Given this list of marker genes HLA-DPA1, COLEC11, CTLA4, YARS2, C1S (complement C1s), TXNDC15, EPG5, ATPAF2, MAB21L1, RAD51, SON, IBA57, WNK3, EIF4A2, LAS1L, AARS1 (NCBI Gene Id 16), OSGEP, KIAA0586 (NCBI Gene Id 9786), CSGALNACT1, B9D2, CD247, DOCK3 (dedicator of cytokinesis 3), FLNB, DNAAF6 (dynein axonemal assembly factor 6), UBA1, HYMAI (hydatidiform mole associated and imprinted), SOST, POMGNT1, HNRNPH2, WBP4, LZTR1, DNAJC30, BBS12, ABCD4, PITX2, OTUD6B, TCF3, BICRA, DBR1, IPO8, SLX4, PARN, SUPT16H, TMEM270, U2AF2, LMNA, FAM50A, RPS28, CRIPT, IARS2, BCR, AGRN, ERCC3, ATP6V0A2, PLAA, CEP55, WDR26, SALL4, ABAT, MOGS, DNAAF5, IVNS1ABP, SEC24C, IFT43, MAN1B1, FIG4, FAM149B1, NEB, SUFU, GTF2IRD1, NDUFB11, KCNJ5, KIF7, MAGEL2, OCRL, BBS4, NOTCH2, INTU, KIF21A, GOLGA2 (NCBI Gene Id 2801), CUL4B, TP53RK (NCBI Gene Id 112858), TBX5, TAPT1, STX1A, AMER1, TAF4, FANCI, DHX9, FLNA, COL11A1, TGIF1, TUBA1A, SLC25A24, BTK, HDAC8, COG8, RTTN, OSTM1 (NCBI Gene Id 28962), TMEM216, CSPP1, HMOX1 (heme oxygenase 1), RYR3, H3-3A, TAFAZZIN, KDM6A, CDT1, TAP2, PEX12, SEC61A1, RPS10, SLC26A2, SEC31A, TNFRSF9, ACTG2, PCDHGC4, DGCR8, UBA2, BRAF, RPS7, ODAD1, CHUK, BANF1 (barrier to autointegration nuclear assembly factor 1), RNF113A, CANT1, RHOA (ras homolog family member A), PIGO, IFT172, C1GALT1C1, FTO, SIM1, GATA4, TRIP4, RAB33B, TBK1, RERE, CHN1, PGM1, COL9A3 (collagen type IX alpha 3 chain), HBB, SYT2, HSD17B4, HSPG2, SETD5, CCDC40, ZMYND10, BUD23, ARMC9, BUB1B, IL2RG, TP63, NME8, GLDN, SMCHD1, MGAT2, MED12, CHSY1, CDC42BPB, SIX1, STAMBP, RFXAP, NFASC, FDFT1, NSUN2, BPNT2, SLC12A2, CDC73 (NCBI Gene Id 79577), IGFALS, COL6A1, PPP1R12A, RPS29, TBC1D2B, CA2, PTPN22, CHST3, NUP88, TERC, TTC8, PEX5, SLC5A7, NELFA, RPS27, ZC4H2, FOCAD, CHD6, CEP295, HS2ST1, DNAAF1, IL6ST, NCF4, CEP290, TENT5A, INTS11, IFT74, SERPINH1, CSNK2B, CDC45, YRDC, EDNRA, COL11A2, TPM2 (NCBI Gene Id 7169), BRIP1, DNMT3A, DOCK8, BICD2, GTF2H5, SLC2A10, RPL31, FANCF, FRMPD4, NSMCE2, ARHGEF38, WDR4, CFI, DNAI2, ABCD1, CTNND2, PNP, DPH5, NCF1, UBAP2L, PLEKHM1 (pleckstrin homology and RUN domain containing M1), CTDP1, HYOU1, RPS20, FOXC2, TMEM107, MDM4, EXTL3, PHF21A, CTC1, FZD2, KLHL41, AP1S2, CREB3L1, DEAF1, MIF, CTSK (cathepsin K), ADAT3, STK36, BRCA1, NHS, MAN2C1, PRKCD, TPRKB, BRF1, ERMARD, ADGRG6, ASPH, HERC1, CSNK2A1, WDR62, HACD1, TRPM3, ATP6V1E1, MAP3K20 (NCBI Gene Id 51784), RFC2, SATB2, KAT6A, DKC1, ATP6AP2, XPA, TRAIP, CHD8, RPL15, IRF2BP2, SLC10A7, ZNF668, AKT1, MECP2, COL2A1, FBXO31, CLIP2, FANCD2, COL1A1 (NCBI Gene Id 4970), SIN3A (NCBI Gene Id 25942), TARS1, ATR, AGA, CTCF, DSE, OTUD5, POLA1 (DNA polymerase alpha 1, catalytic subunit), TAF6, JMJD1C, ZBTB11, PSMC1, GLI2 (GLI family zinc finger 2), FUT8, NCF2, PRKAR1A, ZEB2, LARP7, BMP4, GRIA3, LEMD3, PSAT1, RPGR, MYL11, DVL1, MYH8, MRAS, ARSL, MYPN, DZIP1L, PIK3R1, CFAP300, DNAH7, CNTN1, RAP1B (NCBI Gene Id 5908), ZNF699, COX7B, SCN9A, DPYSL5, DDX3X, SPRTN, NBN, ORC1, DHX30, SLC25A1, DOCK6, BIN1, ELANE (NCBI Gene Id 6417), BUB1, AGL, ESCO2, PEX3, SEC23A, FUCA1, METTL27, VPS53, DLG1, RSPH3, PIGA, PKHD1, FKTN, IDUA, IDS, MAPRE2, WNT5A, CPE, CDH11, ADAMTS10, KDM4B, MLXIPL, LIG4, FOXJ1, SIX3, MBD5, KCNJ2, VPS35L, TRRAP, UBB, PTH1R, RSRC1, UBE3A, EIF4H, POU1F1, COL1A2 (NCBI Gene Id 1278), CD79B, ARX, SCARF2, GHR, DGCR2, EDEM3, DYM, ZBTB20, COL12A1, ERBB3 (NCBI Gene Id 619500), COL9A2, DNAH11, PEX19, CFAP52, FLII, SPAG1, HUWE1, MAP2K2, TBX4, RFX7, SMPD4, NCAPG2, PLA2G6, CYBC1, MITF, ODAD4, NECTIN1, BPTF, PTPN2, KATNB1, MEGF8, KIF26A, STAT4, FILIP1, RAB18, RFX5, ALX4, PCGF2 (NCBI Gene Id 7703), XRCC4, MAMLD1, IRX5, SEC24D, MYMK, RAF1, PQBP1, NEPRO, PIGB, BCL11A, KCNK9, CPLX1, NAA10, SLC12A6, ASXL3, ZNF335, LGI4, HIRA, SMC5, ZNF341, NUP188, SH2B1 (NCBI Gene Id 25970), RPL9, SCAPER, DPM2, LAMA2, KCTD1, ERI1, PEX1, ACTA1, TRIM37, LTBP3, ERCC8, SBDS, SNRPB (small nuclear ribonucleoprotein polypeptides B and B1), MESD, DSTYK, APC2, CENPF, RPS6KA3, CLTCL1, MAPKAPK5, RFXANK, MAD1L1, KPTN, DPYD, GMNN, FANCA, STK4, RFT1, MINPP1, CFAP45, MARS1, SH3KBP1 (SH3 domain containing kinase binding protein 1), UPF3B, NME5, SLC35A3, TBCD, SOX18, POLR1B, NPR3, PLK4, DDB1, CHST14, YY1, MGP, IFT80, ECEL1, NUP85, ZDHHC9, CCNK, RIC1, PAX7, KRAS, PLCB4, PIGW, LARGE1, EXOSC1, MID1, ACSL4, RPS17, PIEZO1, CBFB, C12orf57 (NCBI Gene Id 113246), SCYL2, XRCC2, CRPPA, TNFSF11, UNC119 (NCBI Gene Id 9094), CFL2, COG6, PRIM1 (DNA primase subunit 1), SHH, FOXF1, RPL27, GFPT1, MAP3K7, MYO9A, EZH2, NSD1, PRRX1, TCTN2, HLA-DPB1, BNC2, CLCN7, TFAP2A, SLC26A9, PALB2, TRIP11, SHOX, BDNF, PYCR2, DYRK1A, PRR12, GALNS, DHODH, LRBA, FOXE3, TCTN3, TTN, PI4K2A, PIK3CA, GSC, SHANK3, ADAMTS2, WDR35, HNF1B, TMCO1, MMP2, ZNHIT3, HYDIN, TMEM67, RAPSN, C4B, CFAP418, TINF2, TFE3, LAMB2, WWOX, MAP2K1, ACTG1, CDCA7, COLQ, NSRP1, MTX2, RUSC2, CIITA, CRKL, ARHGAP29, SC5D, TCTN1, INSR, GRIA4, ERCC6, SPRED2, DPAGT1, MRPS22, FANCC, CAVIN1, RSPRY1, ICOS, EFTUD2, FANCE, GNA11, RFWD3, HDAC6, IGF1R, KIF14, GNAS, ANK1, ARID1B, POC1A, H3-3B, PTPN11, MCM5, PRDM13, BRCC3, GPR101, SF3B2, PIGQ, GABRA3, CTBP1, FGFR3, CCDC65, PTEN, RHOBTB2, CHRNE, PKDCC, CTU2, COBLL1, RARB, AIP, PEX13, RAD21, ALG14, PHGDH, TNRC6B, ROBO1, SNRPN, SLC39A7, ANTXR1 (ANTXR cell adhesion molecule 1), CNOT2, FANCL, HBA1, SVIL, PIGU (phosphatidylinositol glycan anchor biosynthesis class U), TGFBR2, CD79A, ADGRG1, UHRF1, KDM5A, ALDH1A2, LBR, NGF, PLXND1, PRUNE1, TBX1, STRA6, DNAAF11, TRIO (NCBI Gene Id 7204), HNRNPH1, VAC14, RNU4ATAC, AFG2B, OPHN1, HMX1, BBIP1, CCN2, FBXO28, CFAP74, PAH, SLC4A10, SOS2, EXOSC5, KCNH1, PGM3 (NCBI Gene Id 5238), PLAG1, GJA8, IGHM, BBS5, IFT27, ANKLE2, FBXO11, SLC6A8, STEEP1, AHDC1, DNAAF4, DLX4, TSR2, POLE, IGHG2 (NCBI Gene Id 3501), ASNS, EIF4A3, COASY, TUBGCP2, GTF2E2, YARS1, CLCN4, AP3D1, CDKN1C, GLE1, BRWD1, RPL10, ANO5, THOC6 (THO complex subunit 6), NFKB1, HNRNPR, HFE, COG5, DDB2, MAPK1, OBSL1, RREB1, GRB10, PSMB8, SLC29A3, FARS2, SPEG, BLTP1, ASXL2, TCIRG1, PEX11B, LOX, NFKB2, CEACAM3, RBM10, NOP10, PUS7, FGFR2, EHMT1, HNRNPU, MAT2A, USB1, PIGN, TOE1, GP1BB, RELN, SPECC1L, TMEM165, SH3PXD2B, SIX5, ABL1, PTCH2, ANKRD11, TRMT1, BRAT1, BBS10, RPGRIP1, MYL2, MSX1, SEMA5A, BBS9, KNL1, LRP4, COG7, LEMD2, PEX6, MAGT1, GPC6, GORAB, FCGR2A, SMAD4, IGLL1, POGZ, MAD2L2, ALMS1, NBAS, NXN, NEK1, DICER1, ZMIZ1, POLR1C (NCBI Gene Id 9533), PGAP2, HPDL, DNAH1, VAMP1, GRIP1, FGFR1, COG1, LMOD3, PIGY, D2HGDH, PUS1, DOK7, APC, PRKG2, TNFRSF13C, GPC3, ERCC2, TERT, H4C5, ROR2, DLK1, IL2RA, TPM3, BLM, LRRC32, RYR1, UNC80 (NCBI Gene Id 84540), IQSEC2, SDCCAG8 (NCBI Gene Id 10806), TAP1, PEX2, TWIST2, GATAD2B, TFAP2B, GLB1, GTF2IRD2, CARS1, CCDC32, COL5A2, EXT2, STXBP2, MYCN, MFAP5, BCAP31, KAT5, SPEF2, ACTB, LRPPRC, EBF3, PDE6D, DPM1, IGF2, PRRT2, PPARG, C1R, GJA5, RPL8, PEX10, PURA, IRF6, PI4KA, IL1RAPL1, NONO, CWC27, CAMTA1, JARID2, FOXG1, TXNL4A, TSEN54, ARVCF, AP2M1, SRPX2, DIS3L2, FANCM, AGPAT2, MEN1, FRA10AC1, NUP133, FKBP6, NARS1, GCLC, PGAP3, COG4, CFAP221, AP4M1, SLC35C1, KCNC2 (potassium voltage-gated channel subfamily C member 2), GBA1, FCGR3A, OCLN, CCBE1, LETM1, WNT7A, TBXAS1 (thromboxane A synthase 1), TTC12, RAI1, CLXN, RNF168, PREPL, ASCC3, KIF11, DHCR7, EP300, AEBP1, NFIX, EMG1, ALG13, GNPTAB, DRC1, PIEZO2, IL21R, DPH2, AFF4, PLAAT3, BUB3, NR2F1, SLC6A14, NDP, ESS2, BGN, ARNT2, DNAI1, CD96, NEK10, SETBP1, CDK5, MAF, TBX15, UBE3B, BMPER, CCDC103, BBS7, RAC2, CC2D2A, RSPH1, P4HB, COL9A1, ANKH, RNU12, SIX2 (SIX homeobox 2), DNAJC21, P4HTM, SPEN, PPP1R15B, RPL26, EDA (ectodysplasin A), RPS19, PHIP, RECQL4, FLCN, EED, VPS13A, CLIC2, H4C3, MEG3, HCCS, VANGL2, NPHP1, IRF8, PAX1, PDE11A, RPL18, ZFX, PYROXD1, ADAMTSL2, FOXI3, EYA1, GRHL3, RUNX2, PIGF, GNB2, PEPD, KMT2A, FOS, TNPO2, TUBB, CNOT1, PRTN3, NRCAM, TWIST1, CAV1, RAB23, KIFBP, RIT1, COL5A1, OTX2, TRPS1, CILK1 (NCBI Gene Id 51541), TASP1, GAD1, EMC1, TGFBR1, MUSK, RPL35, ARID2, RLIM, KCNE5, STAT3, NEDD4L, KCNN4, KMT2D, CREBBP, PSPH, THUMPD1, DDR2, ESAM, TUBB3, ODAD3, RECQL, B3GALT6, MAFB, IGKC, RTL1, RBBP8, DNAL1, SPOP, IKBKG, RB1, LAGE3, KL, PEX7, RTEL1, HELLS, BRD4, RAB34, DNAAF2, DNMT3B, EFL1, BSCL2, EXT1, HDAC4, EBP, TOPORS, ATM, RSPH9, UBE2A, LRRC56, XPC, SMS, SLC9A6, ACP5, PIGG, TBL2, MED13L, CDC6, CHRNG, SELENON, FOXE1 (NCBI Gene Id 7081), PDZD8, IL2RB, CENPE, CEP152, MYLK, HYLS1, ORC6, FGF3, TRIM32, TELO2, TAT, CSF1R, CASK, RPS15A, PDGFRB, SLC39A14, GNPAT, FBXW11, MAPK8IP3, CNTNAP2, MKKS, CACNA1G, NOTCH3, CLPB, GPKOW, NTRK1, HNRNPK, ANAPC7, NDST1, SMO, FANCG, SLC35D1, LTBP4, POMT2 (protein O-mannosyltransferase 2), SF3B4, MTM1, PAX6, MYBPC1, EFEMP2, ZBTB18, STT3A, RPS24, CDK10, LRRC8A, AUTS2, STAG2, DNA2, POLR1D, CCDC39, SLC11A1, CRTAP, SMG8, TGFB2, CENPJ, WIPF1, CLCF1, COL3A1, TGFB3, DGCR6, LRP2, C2CD3, MADD, RSPO2, ACBD6, SOBP, CUL7, TBX22, COL25A1, SETD2, BBS1, CAPRIN1 (cell cycle associated protein 1), IL11RA, ODC1, PIK3CD, MYO18B, PLVAP, FAM20C, PRMT7, SLC6A9, WDR73, CRLF1, IL17RA, PEX16, STAC3, AIFM1, LIMK1, ITGA7, ADAMTSL1 (NCBI Gene Id 92949), SLC6A17, SPRED1, RSPH4A (NCBI Gene Id 345895), ERCC5, ALG12, CHD5 (NCBI Gene Id 26139), NUDT2, EDN1, RASA2, POLR3A, ATRX, WNT3, LRP5, TNFRSF13B, ATAD3A, CLCA4, IRF1, ADAMTSL4, RPGRIP1L, SASH3, CRELD1, CEP135, RRAS, FANCB, PIGL, TOMM7, RAP1GDS1, FMR1, NEK9, COL13A1, RPL11, NSDHL (NCBI Gene Id 50814), DCHS1, ERGIC1, PUF60, PAK2, SNIP1 (NCBI Gene Id 79753), GNAI3, PRKACA, PIK3C2A, NDE1, H4C9, RPS26, PCNT, SCO2, CHRND, GTF2I, DHCR24, UBE2T (ubiquitin conjugating enzyme E2 T), B3GLCT, MIA3, MIPEP, SCN4A, PYCR1, TRMT10A, TYMS (thymidylate synthetase), ORC4, ERCC1, MTHFR, CBL, SRCAP, SSR4, CCNO, SH3BP2, PSMC3, SCLT1, ASPM, PIGT, CHRNA1, PEX26, MYH3, RMRP (NCBI Gene Id 6023), FKRP, ATP6V1B2, TBCE (NCBI Gene Id 6905), TGDS, WDPCP, KDM5C, FBN1, TNFRSF11A, FGD1, MCTP2, ITGA8, IGF1 (NCBI Gene Id 3479), AMMECR1, ATP10A, FOXN1, PRORP, FGF10, CYBB, ASXL1, SP7, RAC3, TMEM70, ACTA2, PLAGL1, PSMB4, B9D1, ARL6IP6, WDR11, AIRE, SMC3, MED25, TRIP13, HS6ST2 (heparan sulfate 6-O-sulfotransferase 2), CCDC88A, ALG1, SFRP4, PNKD, TMEM237, IDH1, RNF125, RAB3GAP1, MSTO1, CHD7, TBC1D20, PIGV, GATA1, MSL3, ICOSLG, CEP120, VPS13B, SOS1, ERCC4, TAF1, EXOC7, ELN, POMT1, ZMPSTE24, FOXC1, ATP7A, DYNC2H1, PRKACB, GPC4, INPPL1, LMBRD2, RBM8A, PDE4D, PLOD3, SMAD2, SMAD3, NIPBL, RPL35A, BCL11B, ATP6V0A1, FLVCR2, TCOF1, SUZ12, DONSON, KIDINS220, STAG1, THSD4, IGBP1, SLC37A4, DPH1, SOX5, SRY, DNAJB13, RAD51C, DNAH5, CEP57, DNAH9 (NCBI Gene Id 8709), CR2, AFG2A, SMOC1, BBS2, TBC1D7, NFKBIA, PTCH1, CD19, ALX1, CFTR, MYH7, NALCN, TBL1XR1, REV3L, B4GALT7, MAN2B1, COMT, DNAAF3 (dynein axonemal assembly factor 3), SOX6, LZTFL1, ALX3, NPM1, HMGA2, ANKRD55, DLG3, OCA2, TBCK, RIN2, HDAC9, RPL5, CXCR4, POLR1A, MYOD1, KDM6B, WASHC5, KCNJ6, MKS1, ATG7, ARCN1, FBXL3, SLC35B2, GON7, FOXP1, BAZ1B, HBA2, SERPINA1, ALG9, NRAS, HOXB1, SLC25A19, SPI1, AIMP2, ADA2, IGSF3, GDF11, NF1, LIFR, IKBKB, KMT2B, PPP3CA, TONSL, MCIDAS, SKI, SMC1A, HEATR3, PSMD12, NSD2, HECTD4, FAT4, BRCA2, CHAT, MYH11, WBP11, CFAP298, CPLANE1, WAS, CNOT3, VARS1, ATP6V1A, KAT6B (NCBI Gene Id 23522), RAB3GAP2, RIPK4, INTS1, CNTNAP1, OFD1, SNAP25, FGFRL1, FOXP2, TNNI2, TGFB1, CACNA1C, SLC9A3, GLI3, BLNK, CEP19, GAS2L2, KIF22, GJA1, SLC35A2, HRAS (NCBI Gene Id 338029), POLD1, POR, RDH11, PEX14, NUP107, CEACAM6 (NCBI Gene Id 4680), DCTN4, DVL3, RNU4-2, ERF, KIAA0753, NHP2, MPDU1, GEMIN4, FHL1 (four and a half LIM domains 1), KBTBD13, PMM2, SCNM1, TMEM231, CYBA, PDGFRA, EIF5A, SLC3A1, ADA, KIF15, ATRIP, B3GAT3, ARL6, ODAD2, DDX59, CLCN3, NAA80, TOR1A, VPS37D, COL6A2, PTDSS1, KCNK4, ACAN, WLS, FBN2, AFF3, GSTM3, BMP2, CDH1, HEY2, KCNN3, TNNT3, DYNC2I1, ZBTB24, ADAMTS3, UFD1, FAM111A, IFT140, WRAP53, SOX9, COL6A3, CCDC22, IFIH1, ZNF292, SEMA3E, ALG11, WT1, VPS33B, MPLKIP, RRAS2, HERC2, NEXMIF, DYNC2I2, PAX3, PRKG1, MYMX, SLC18A3, FBXL4, here is a description of the gene set: Abnormal facial skeleton morphology studied in species Homo sapiens An abnormality of one or more of the set of bones that make up the facial skeleton. Human Gene Set: HP_ABNORMAL_FACIAL_SKELETON_MORPHOLOGY